The following is a description of a gene set: from publication Chen Y, Wang X (PMID 31504780) species: Homo sapiens Human Gene Set: MIR767_3P Genes predicted to be targets of miRBase v22 microRNA hsa-miR-767-3p in miRDB v6.0 with MirTarget v4 prediction scores > 80 (high confidence targets)., and this is the list of marker genes: ARID5B, PCDHA9, FBXO9, AMMECR1L, SPOP (NCBI Gene Id 8405), PCDHA13, LRRC32, CHRD, JPH3, SZRD1, PRKAR2A, EIF4E2, PCDHA2, MTMR4, AKAP4, POGLUT1, ARMH3, TNS2, ARAP2, SORT1, LATS2, GJB2, PCDHA11, SCRN3, CARD6, SET, ACADSB, PTCH1, PCDHA4, SEC61A1, CNR1, ZEB2, PCDHA3, MAPK8, PRICKLE1, UPF2, HSPA9, THSD7A, ZNF112, CLDN18, SHISAL1 (shisa like 1), PPP1R1C, PCDHAC2, USP4, PCDHA7, PCDHA12, KLHL2, NIPAL3, HIF1A, ARL14EP, GPATCH2, SCN9A, SPPL2B, PCDHA5, UBN1, SERTAD2, DNAAF9 (NCBI Gene Id 348549), ZNF710, RPE, TIAM2, ADCYAP1R1, TAB2, METTL23, AAK1, USP9Y, TXNL4B, RAP2A, S100A10, KPNA6, CT55, JTB, PCDHA10, FHL1, RBM12, MLH3, PCDHA1, UGT2B17 (UDP glucuronosyltransferase family 2 member B17), KDELR3, UPF3A, THRAP3, P2RX2, FAM204A, MRPS25, HOMER2, SLC35B4, SMAD2, PCDHA6, BBX, BAIAP2, UBE2N, CHAC1, ZNF518B, GAREM1, ARFGEF1, CPEB3, ZNF146, PTPRT, UNKL, CEP170B, KLHL1, TRIM23, SORL1, ZNF267, FUT1, ARID2, DONSON (NCBI Gene Id 55597), DOCK10, NFASC, ATXN7L3B, CLMN, SIRPB1, SLC4A10, ZNF778, CCDC126, MTOR, SAP30L, VSTM2L, JMJD7, PCDHAC1, ENOSF1, ARMH4, JARID2 (NCBI Gene Id 3720), PPM1B, CNOT8, NEFH